Given this list of marker genes H4C9, GDF5, GJB6, ADAMTSL1, KANSL1, FLNB, BAP1, MMP2, PHGDH, ADAT3, HADHA, WRN, RNU12, MAFB, DPH5, SMOC1, PSAT1, OBSL1, PHEX, RELN, MKKS, EXOC7, NUP188, CUL7, SOX4, KATNB1, AEBP1, HADHB (NCBI Gene Id 3032), EN1, IPO8, SLC35D1, MATN3, VAC14, RTL1, PTH1R, EPB41L1, LEMD3, ZMPSTE24, MAP3K7, LMNA, CANT1, COL1A2, FGFR2, GDF6, NOG, GPX4, CHRNG, HDAC6, TOR1A, NGLY1, RSPRY1, EIF2AK3, MAF, COL2A1, INPPL1, ZC4H2, PLAA, PUF60, NDE1, GLI3, ATP6AP2, FGFR1, EBP, SAMD9, CHSY1, SLC2A10, ARID1B, RAB33B, SATB2, MUSK, WNT7A, ERCC5, POR (cytochrome p450 oxidoreductase), COL11A2, DOK7, HOXA13, TBX4, TNNI2, DYM, SMPD4, LMBR1, MAGEL2, ATPAF2, MET (NCBI Gene Id 4233), MYH3, OTUD5, NALCN, FIG4, EZH2, FBN1, LBR, TELO2, MYBPC1, SCYL2, AARS1, ERCC6, TNNT3, ITPR1, ATP7A, CCDC8, EXT1, ZEB2, MYL11, ERCC2, GLE1, SYT1, OFD1, HOXD10, PEX1, CLTCL1, ERGIC1, FLNA, RBM10, NUP88, GJB2, DLK1, COL25A1, COASY, ERCC1, FBLN1 (fibulin 1), MEG3, FGFR3, EMG1, TPM2, SLC29A3, MMP14, EXT2, KIF14, BMPR1B, ECEL1, FILIP1, GFM2, here is a description of the gene set: studied in species Homo sapiens An abnormality of the tarsus are the cluster of seven bones in the foot between the tibia and fibula and the metatarsus, including the calcaneus (heel) bone and the talus (ankle) bone. Human Gene Set: HP_ABNORMALITY_OF_THE_TARSAL_BONES Abnormality of the tarsal bones